The following is a description of a gene set: studied in species Mus musculus Any process that modulates the frequency, rate or extent of phosphatidylcholine biosynthetic process. Mouse Gene Set: GOBP_REGULATION_OF_PHOSPHATIDYLCHOLINE_BIOSYNTHETIC_PROCESS, and this is the list of marker genes: Lpcat1, Acsl3 (acyl-CoA synthetase long-chain family member 3), Capn2, Rab38, Fabp3